The following is a description of a gene set: Enables the transfer of a solute or solutes from one side of a membrane to the other according to the reaction: Na+(out) + phosphate(out) = Na+(in) + phosphate(in). Human Gene Set: GOMF_SODIUM_PHOSPHATE_SYMPORTER_ACTIVITY studied in species Homo sapiens, and this is the list of marker genes: SLC17A6, SLC17A1, SLC20A1, SLC17A2, SLC17A4, SLC34A2, SLC17A3, SLC17A7, SLC34A1, SLC17A8, SLC34A3, SLC20A2